The following is a description of a gene set: Mouse Gene Set: REACTOME_GABA_RECEPTOR_ACTIVATION GABA receptor activation species: Mus musculus, and this is the list of marker genes: Adcy7, Adcy9, Kcnj2, Gnb4, Gabra1 (NCBI Gene Id 14394), Gnb2, Kcnj3 (potassium inwardly-rectifying channel, subfamily J, member 3), Gabra5, Gngt2, Kcnj16, Gng13, Kcnj5, Gabra3, Gng3, Gnal, Gabrg2, Kcnj12, Adcy1 (NCBI Gene Id 52867), Gngt1, Gabrr3, Gnb5, Gnai2, Gabra6, Gng2, Gnb3, Gabrq, Adcy3, Gabbr2 (gamma-aminobutyric acid type B receptor subunit 2), Adcy6, Gng8, Gabrb2, Gabra2, Gng4, Gabrb3, Kcnj15, Gng11, Gng5, Kcnj6, Kcnj4, Gabrr2, Adcy8, Gnb1, Gabrg3, Adcy4, Gng7, Adcy2, Gabbr1, Gabra4, Kcnj9, Kcnj10, Gng12, Gabrb1, Gng10, Gnat3, Gnai1, Adcy5, Arhgef9, Gabrr1, Gnai3